The following is a description of a gene set: Synthesis of 15-eicosatetraenoic acid derivatives Mouse Gene Set: REACTOME_SYNTHESIS_OF_15_EICOSATETRAENOIC_ACID_DERIVATIVES studied in species Mus musculus, and this is the list of marker genes: Gpx4, Alox15, Alox8, Gpx2, Gpx1, Ptgs2